The following is a description of a gene set: STAT3, an essential transcription factor with pleiotropic functions, plays critical roles in the pathogenesis of autoimmunity. Despite recent data linking STAT3 with inflammatory bowel disease, exactly how it contributes to chronic intestinal inflammation is not known. Using a T cell transfer model of colitis we found that STAT3 expression in T cells was essential for the induction of both colitis and systemic inflammation. STAT3 was critical in modulating the balance of T helper 17 (Th17) and regulatory T (Treg) cells, as well as in promoting CD4+ T cell proliferation. We used chromatin immunoprecipitation and massive parallel sequencing (ChIP-Seq) to define the genome-wide targets of STAT3 in CD4+ T cells. We found that STAT3 bound to multiple genes involved in Th17 cell differentiation, cell activation, proliferation and survival, regulating both expression and epigenetic modifications. Thus, STAT3 orchestrates multiple critical aspects of T cell function in inflammation and homeostasis. from publication Durant L, Watford WT, Ramos HL, Laurence A, Vahedi G, Wei L, Takahashi H, Sun HW, Kanno Y, Powrie F, O'Shea JJ (PMID 20493732) Human Gene Set: GSE21670_STAT3_KO_VS_WT_CD4_TCELL_TGFB_TREATED_DN studied in species Homo sapiens Genes down-regulated in CD4 T cells treated with TGF beta: STAT3 knockout versus wildtype., and this is the list of marker genes: CEACAM20, TYR, CPED1, RFC1, OR2S2, RPF2, INCENP, CHRDL2, B3GALT1, ITGAX, CA8 (carbonic anhydrase 8), MCM10, FAIM2, CFAP91, TRIP13, NECTIN1, SMARCC1, PAK6, STARD8, ABCA4, SNX7, GINS1 (NCBI Gene Id 9837), CLEC1A, FIGN, NRIP2, TMEM116, IRF8, RAB3A, EFCAB6, HOXA13, GARIN1B, AK7, SLC27A2, OSCP1, SUN5, FHL1, WNT9B, ATP2B3, MORN4, AGBL5, VSTM2B, BCAT1, CATSPERZ, SCG2, AEN, SLC39A3, DACH1, FBN2, NXPH4, ALG8, MRPS6, CDK6, KCNMB2, PDK4, NEUROD4, PTCHD4, LMNB2, GAN, TLX2, POLR3K, LNX1, ELN, CACNG8, NALF1, NT5DC3, ZNF572, SIRPB1, BPIFA3, MRAP (NCBI Gene Id 56246), FERD3L, RNF26, NMUR1, PPP1R13L, COG8, SLCO4A1, ALCAM, STMND1, BRCA1, SEMA3C (NCBI Gene Id 222200), PBK, NETO2, SAMD11, RNF144B, MFSD6, TFAP2C, HOXB2, APEX1, ARHGAP11A (Rho GTPase activating protein 11A), LRRC46, SLC9A2, ZFAND4, HOXC13, MTG1, TSN, POU4F1, NELL1, MDGA2, FCSK, MXD3, NETO1, B4GALNT2, KNTC1, IMPDH2, SNHG10, SEMA3F, ADCK1, KIF2C, MATCAP2, OSCAR, IFT57, KLHDC10, PFN2, IGF2BP1, NUP133, PSAT1, KCTD8, PLPPR3, PON1, OR2C1, SRR, USH2A, SHH, AARS1, PRL, UNG, NSL1, CAPN12 (NCBI Gene Id 337935), AGMAT, MEG3, ATAD5, PREB, AIF1L (allograft inflammatory factor 1 like), LMNTD1, NEK6, C1orf54, PDGFA, ADAMTSL1, CMC2, PARN, TRUB2, UROC1, NOC4L, E2F3, TM7SF2, PWP2, HMGN3, IL36G, LHFPL5, IGSF1, DGLUCY, ERCC6L, VKORC1L1, PLCG2, ERCC1, GRIK2, MRPL44, SEPHS2, TPMT, SPAG4, SCRG1, PAK3, ADAM11, LGALS7, FOXM1, SAMD5, SPC25, IGSF9, LLCFC1, TBX22, PPFIA3, NSUN7, FCER2, MST1R, RNF182 (ring finger protein 182), COL17A1, YBX3, BNC2, KIF13A, USP54, POLR1C, LHFPL4, TNNI2, E2F7, GLIS2, INSYN2A, NAF1, CAMSAP2, TIMM44, FAT4, MAP3K9, RMDN3 (NCBI Gene Id 55177), TRIB3, CLU, ADAM21, LGI1, CFHR2, NRCAM, INHBE, KCNN3